The following is a description of a gene set: The directed movement of a protein from the nucleus into the cytoplasm. studied in species Mus musculus Mouse Gene Set: GOBP_PROTEIN_EXPORT_FROM_NUCLEUS, and this is the list of marker genes: Fam76b, Sp100, Ankle1, Ran, Ranbp17, Cdk5, Nup214, Chchd4, Gsk3b, Ranbp3l, Bag3, Adar, Park7, Ctdspl2, Tgfb1, Xpo1, Rangap1, Stradb, Cdkn2a, Pkd1, Xpo6, Calr (calreticulin), Frat1, Txn1, Rbm22, Xpo7, Frat2, Nutf2-ps2 (nuclear transport factor 2, pseudogene 2), Prkaca, Ptpn11, Wipf1, Hdac3, Anp32b, Sfn, Xpo4, Camk4, Ranbp3, Ahcyl1, Mdm2, Chp1, Bard1, Nxt1, Sirt7, Ifi27, Uhmk1, Prkd1, Ppm1a, Rapgef3, Strada, Xpo5, Peg12, Ywhae, Cchcr1, Tpr, Cse1l, Sirt6, Ptpn14, Egr2, Hspa9, Prpf4b, Nutf2, Nutf2-ps1, Emd, Gas6, Desi1, Camk1, Smurf1